The following is a description of a gene set: studied in species Homo sapiens Human Gene Set: BLANCO_MELO_COVID19_BRONCHIAL_EPITHELIAL_CELLS_SARS_COV_2_INFECTION_DN from publication Blanco-Melo D, Nilsson-Payant BE, Liu WC, Uhl S, Hoagland D, Møller R, Jordan TX, Oishi K, Panis M, Sachs D, Wang TT, Schwartz RE, Lim JK, Albrecht RA, tenOever BR (PMID 32416070) Analysis of the transcriptional response to SARS-CoV-2 compared with other respiratory viruses, including MERS-CoV, SARS-CoV-1 (SARS), human parainfluenza virus 3 (HPIV3), respiratory syncytial virus (RSV), and IAV., and this is the list of marker genes: CDH10, RAB15 (NCBI Gene Id 376267), DBP, TMT1A, GPNMB, MIR221, PDK4, LY6D, VTCN1, KRT15, SELENOP, TFCP2L1, CYP4F3 (cytochrome P450 family 4 subfamily F member 3), OLFML2A, MXRA5, SPTLC3, STON1, IRF2BPL, MN1, MAF, TCN1, CD86, HSD17B3, BLNK, THBD, ALDH3A1, MAP7D2, ENSG00000289047, NID1, PDE5A, RAB30, NANOS1, PROS1, PBX1, EFCAB7, SOX6, GULP1, IFITM10, CREG2, FGF1, SYTL5, PADI3, PCDH7, IRAG2, EPHA4, EXTL2, SEMA3E, CENPA, PPARGC1A, ATG9B, VAV3, MYLK, PTPRZ1, CXCL14, CYP2B7P, TSC22D3, RBM20, ZNF488, BBOX1